Given this list of marker genes Dnmt1, Olfm2, Myocd, Pdgfb, Sod2, Fgf9, Ehmt2, here is a description of the gene set: Mouse Gene Set: GOBP_PHENOTYPIC_SWITCHING studied in species Mus musculus A reversible switch of a cell from one cell type or form to another, at a frequency above the expected frequency for somatic mutations. Phenotypic switching involves changes in cell morphology and altered gene expression patterns. For example, Candida albicans switches from white cells to opaque cells for sexual mating. Phenotypic switching also occurs in multicellular organisms; smooth muscle cells (SMCs) exhibit phenotypic transitions to allow rapid adaption to fluctuating environmental cues.